The following is a description of a gene set: species: Homo sapiens Any process that modulates the physical form of a presynapse. Human Gene Set: GOBP_REGULATION_OF_PRESYNAPSE_ORGANIZATION, and this is the list of marker genes: CLSTN3, SLITRK2, NTRK3, IL1RAPL1, WNT7A, CBLN1, NLGN2, SLITRK1, EIF4G1, MDGA1, SLITRK3, FARP1, NRXN1, CACNA2D3, APP, FZD1, WNT3A, IL1RAP, LRRTM3, GRID2, IL1RAPL2, SNCA, LRFN4, GPC4, LRRC4B, MIR431, ARF6, NTNG2, LRFN5, IGSF11, VPS35, DKK1, LRFN3